Given this list of marker genes CFL2, DCTN1, CCNF, LMOD3, UNC13A (unc-13 homolog A), SQSTM1, GLT8D1, FIG4, MATR3, TAF15, PON1, ATXN2, HNRNPA1, RNASEH1, CHMP2B, DAO, CHRNE, MUSK, COL13A1, AGRN, TREM2, CFAP410 (cilia and flagella associated protein 410), PPARGC1A, SOD1, PRPH, GLE1, CHRNA1, DES, RAPSN, CHRNB1, NEB, CHCHD10, ERBB4, KLHL41, ANG, VAPB, FUS, UBQLN2, LRP4, NEFH, CHRND, DOK7, TARDBP, OPTN, AK9, VCP, KCNE3 (potassium voltage-gated channel subfamily E regulatory subunit 3), PFN1, RRM2B, PON2, TBK1, ACTA1, NEK1, ANXA11, PON3, CACNA1S, SCN4A, TPM2, here is a description of the gene set: Fatigable weakness of respiratory muscles Human Gene Set: HP_FATIGABLE_WEAKNESS_OF_RESPIRATORY_MUSCLES A type of weakness of the muscles involved in breathing (respiration) that occurs after a muscle group is used and lessens if the muscle group has some rest. That is, there is diminution of strength with repetitive muscle actions. studied in species Homo sapiens